Given this list of marker genes LGALS7, CLCA2, SLC39A6, SPRR1B (small proline rich protein 1B), S100P, KRT75, KRT6A, CA12, S100A8, DST, JAG1, PTGES, PKP1, IVL, CXCL14, S100A2, SDC1, AMIGO2, SLPI, CSTA, DSG1, FEZ1, S100A9, GJA1, ITGA6, NSG1, NDRG1, P3H2, TP63, PDPN, AQP3, SPRR1A, TRIM29, PTHLH, GPX2, FLRT3, PTPRZ1, DSC3, PI3, GJB5, HTRA1 (HtrA serine peptidase 1), SERPINE2, SFN, KRT16, S100A7, MFAP5, IL1A, FABP5 (NCBI Gene Id 92424), POSTN, MMP10, IL1B, RHCG, AKR1C1, here is a description of the gene set: Genes up-regulated in basal mammary epithelial cells compared to the luminal ones. studied in species Homo sapiens Epithelial cells within the normal breast duct seem to be the primary target for neoplastic transformation events that eventually produce breast cancer. Normal epithelial cells are easily isolated and propagated using standard techniques. However, these techniques almost invariably result in populations of cells that are largely basal in character. Because only approximately 20% of human breast cancers exhibit a basal phenotype, our understanding of the disease may be skewed by using these cells as the primary comparator to cancer. Further, because germ line mutations in BRCA1 yield breast cancers that are most often of the basal type, a comparison of normal basal and luminal cells could yield insight into the tissue and cell type specificity of this hereditary cancer susceptibility gene. In this report, we describe a simplified and efficient method for isolating basal and luminal cells from normal human breast tissue. These isogenic cells can be independently propagated and maintain phenotypic markers consistent with their respective lineages. Using these cultured cells, we show that basal and luminal cells exhibit distinct responses to ionizing radiation. Basal cells undergo a rapid but labile cell cycle arrest, whereas luminal cells show a much more durable arrest, primarily at the G(2)-M boundary. Molecular markers, including p53 protein accumulation, p53-activated genes, and BRCA1 nuclear focus formation all correlate with the respective cell cycle responses. Further, we show that short-term cultures of human breast tissue fragments treated with ionizing radiation show a similar phenomenon as indicated by the biphasic accumulation of p53 protein in the basal versus luminal layer. Together, these results indicate that normal basal cells have a transitory cell cycle arrest after DNA damage that may underlie their increased susceptibility to transformation after the loss of functional BRCA1. Human Gene Set: HUPER_BREAST_BASAL_VS_LUMINAL_UP from publication Huper G, Marks JR (PMID 17409405)